Given this list of marker genes PIK3CA, BCL2, ZNF304, SNAI2, SRC, NOTCH1, PTRH2, TLE1, NTRK2, PTK2, CEACAM6, PIK3R3, CEACAM5 (NCBI Gene Id 1048), PDK4, ITGB1, BCL2L1, CAV1, ITGA5, MCL1, here is a description of the gene set: Human Gene Set: GOBP_NEGATIVE_REGULATION_OF_ANOIKIS Any process that stops, prevents or reduces the frequency, rate or extent of anoikis. species: Homo sapiens